The following is a description of a gene set: Mouse Gene Set: GOCC_OUTER_KINETOCHORE studied in species Mus musculus The region of a kinetochore most external to centromeric DNA; this outer region mediates kinetochore-microtubule interactions., and this is the list of marker genes: Ndc80, Nuf2, Spc25, Spc24, Bod1, Bub1b, Spdl1, Crebbp, Mis12, Ska1, Pmf1, Plk1, Bub1, Nsl1, Ska3, Cenpf, Ccnb1, Zwint, Cenpe, Ska2, Knl1, Dsn1 (NCBI Gene Id 99407), Ccnb1-ps